Given this list of marker genes Jak2, Il23r, Il12rb1, Il12b, Il12a, here is a description of the gene set: Binding to an interleukin-12 receptor. species: Mus musculus Mouse Gene Set: GOMF_INTERLEUKIN_12_RECEPTOR_BINDING